The following is a description of a gene set: studied in species Homo sapiens Human Gene Set: GOBP_POSITIVE_REGULATION_OF_REGULATORY_T_CELL_DIFFERENTIATION Any process that activates or increases the frequency, rate or extent of differentiation of regulatory T cells., and this is the list of marker genes: TGFB1, CD46, IL2, AMBRA1, HLA-G, SOCS1, LGALS9, LILRB4, CR1, LILRB2 (NCBI Gene Id 10288), KAT5, BCL6, IFNG, BTN2A2, IL2RG, DUSP10, FOXP3, FOXO3, HLA-DRB1, IL4I1, SOX12, HLA-DRA, VSIR, KLHL25